Given this list of marker genes CEP55, FLNA, SV2B, ATIC, FASN, WDR12 (WD repeat domain 12), PDIA5, PTPN6, FAM124B, PLXNA2, TREM1, CTNNAL1, PLSCR3, AIF1, BRCC3, CLTA, ACOT7, DET1, MYBL1, NUSAP1, SPR, RRP7A, NT5DC2, RFC4, MCM5, POP5, SEC13, VBP1, TBCD, DDX39A, COX6C, SLC2A3, GPSM2 (G protein signaling modulator 2), CSRP1, NDUFS1, PSMC1, TPX2, P2RY6, GTF2F1, FH, ATP2A2 (NCBI Gene Id 488), COQ9, MCM2, ATP5MJ, GYG1, PSMB6, PCCB, PSMD8, PSMC4, IFI35, P4HB, EMC6, ECM1, PSTPIP1, PSME2, ARF3, MIPEP, KIF20A (kinesin family member 20A), TMPO, MAPKAPK3, AATF, FANCI, TPMT, MCUB, DHCR24, MKI67, CDC25A, COX17, HJURP, LASP1, CFAP298, ATP5F1B, APEH, OPRM1, DUSP6, HK1, DONSON, TUBA3D, OTULINL, CDCA3, SLC31A1, BAK1, PRIM1, MYO1B, APOBEC3B, ETV5 (ETS variant transcription factor 5), NCAPG2, SH3BGRL3, TUBG1, NDC1, UBE2C, CCT4, FZD5, TCIRG1, MAGOHB, PSMD6, PSMA7, DNAJC9, FCGR1BP, P4HA2, ACTR1A, CDC45, TIGAR, CAPN2, MRPS12, HSPD1, GPI, SNAP29 (NCBI Gene Id 9342), GOT1, TUBB2A, EMC8, RAC2, SEPTIN8, DEF6, PSMB1, PPBP, NCAPG, XPO1, PSMB7, POMP, PEX10, DPP3, IPO4, PROCR, ATP5PD, E2F8, CEMIP2, CANX, UQCRQ, POTEKP, TTC1, PGAM1, PITPNC1, EAF2, NOP10, RPA3, IPCEF1, GFUS, ABHD2, EIF2S1 (NCBI Gene Id 1965), ALDH18A1, ICMT, HPGDS, NMT1, ARF1, PARP11, COPS7A, COX7A2, S100A6, EXOG, CCNB1, CKS2, ILF2, THBD, KPNA2 (NCBI Gene Id 728860), GALE, SPP1, ATP5MF, ZWINT, EIF4G3, NISCH, COX6A1, PARP1, MRPS14, KIF4A, PAICS, TK1, CCNB2, ACLY, COX5A, PDLIM5, HK2, SLC22A18AS, TUBB, LAMTOR5, MRPS28, BST1, HTT, RPP40, RAN, COX5B (NCBI Gene Id 1329), FCN1, ACOT9, FBXO5, ABCB4, BLVRA, ALOX5AP, ISG15, NDC80, AARSD1, RANBP1, POLR2L, RRM1, TM9SF2, ARPC5L, PSMD11, GCLM, FKBP1B, ROGDI, RACGAP1, here is a description of the gene set: Genes up-regulated in lesional skin biopsies after S. aureus infection: wildtype versus IL1R1. from publication Cho JS, Guo Y, Ramos RI, Hebroni F, Plaisier SB, Xuan C, Granick JL, Matsushima H, Takashima A, Iwakura Y, Cheung AL, Cheng G, Lee DJ, Simon SI, Miller LS (PMID 23209417) Neutrophil abscess formation is critical in innate immunity against many pathogens. Here, the mechanism of neutrophil abscess formation was investigated using a mouse model of Staphylococcus aureus cutaneous infection. Gene expression analysis of S. aureus-infected skin revealed that induction of neutrophil recruitment genes was largely dependent upon IL-1beta/IL-1R activation. Unexpectedly, using IL 1beta reporter mice, neutrophils were identified as the primary source of IL-1beta at the site of infection. Furthermore, IL-1beta-producing neutrophils were necessary and sufficient for abscess formation and bacterial clearance. S. aureus-induced IL 1beta production by neutrophils required TLR2, NOD2, FPRs and the ASC/NLRP3 inflammasome. Taken together, IL-1beta and neutrophil abscess formation during an infection are functionally, spatially and temporally linked as a consequence of direct IL-1beta production by neutrophils. Human Gene Set: GSE36826_WT_VS_IL1R_KO_SKIN_STAPH_AUREUS_INF_UP species: Homo sapiens